The following is a description of a gene set: species: Homo sapiens Genes predicted to be targets of miRBase v22 microRNA hsa-miR-325 in miRDB v6.0 with MirTarget v4 prediction scores > 80 (high confidence targets). Human Gene Set: MIR325 from publication Chen Y, Wang X (PMID 31504780), and this is the list of marker genes: KTI12, PLD1, UTP23, ARRDC3, ABRAXAS2, ATG12, CSNK1A1, CELF1, NR2C1, MAGOHB, TTLL7, DDX5, KCNV1, TYW1B, PREX2, TRIM9, PPTC7 (NCBI Gene Id 160760), ISOC1, DNAJB9, GKN1, RIMS1, ZNF225, TPPP, HIRA, SMCHD1, GRIA4, ROCK1, WNK1, PACC1, DNASE2